Given this list of marker genes Meg3, Zmpste24, Mfsd8, Norad, Atp8a2, Atp1a3, Ankle1, Sirt6, Enpp1, Sod1, Dmd, Wrn, Ercc5, Lep, Icmt, Rad54b, Trex1, Htt, Ercc1, Tmem135, Kl, Cgas, Kcnj8, Cfh, Scn1a, Coq7, Prdm2, Scn2a, Sgsh (NCBI Gene Id 27029), Inpp5d, Lipa, Kcnq2, Lrrk2 (NCBI Gene Id 79409), Pou1f1, Terc, B4galnt1, Msh6, Atn1, Tfcp2l1, Rad54l, Dnaaf3, Suv39h1, Bbc3, Msh2, Polg, Ercc2, Hdac9, Trp63 (NCBI Gene Id 22061), Naglu, Ghrhr, Atm, Trp53, Large1, Kcnj11, Gba1, here is a description of the gene set: The pathways that regulate the duration of the adult phase of the life-cycle of an animal. Mouse Gene Set: GOBP_DETERMINATION_OF_ADULT_LIFESPAN species: Mus musculus